Given this list of marker genes Il23r, Erap1, Spred1, Adam8, Smad3, Il3, Snx25, Nsmaf (NCBI Gene Id 93775), Ntf5, Ifna4, Trim37, Ccl22, Cxcl11, Ltb, Tslp, Tnfsf14, Bex3, Gm6040, Prl7a2, Defb47, Ccl8 (NCBI Gene Id 80561), Cxcl3, Cnih4, Eng, Smurf2, Il36a, Prl7a1, Ripk1, Ccl24, Tgfbr3l, Ccl2, Ifna9, Syk, Tgfb3, Ifng, Eda, Defb15, Ccrl2, Crlf1 (cytokine receptor-like factor 1), Ifna12, Stap1, Dnaja3, Gm13272, Gm13283, Pgf, Cd2ap, Pycard, Fadd, Prl3d2, Ccl3, Il10, Tgfbrap1, Ctf2, Ifnl3, Defb48, Msmp, Ifnz, Tgfb2, Pf4, Cd300lf, Ccl17, Cxcl17, Il27, Jak2, Ccl20, Tnfsf12, Cxcl15, Snx6, Prl6a1, Cd40lg, Tgfbr1, Ccl5, Prl5a1, Defb8, Traf2, Traf4, Xcl1, Smad6, Ccl19, Ccl27a, Tlr5 (NCBI Gene Id 53791), Spred3, Ifna13, Zfp110, Tollip, Sh2b3, Il6ra, Ccdc88a, Vegfc, Bdnf, Casp3, Ntrk1, Plcg1, Prl2c2, Ccl1, Ccl19-ps1, Nradd, Ccl4, Csf1, Ddt, Tnfsf4 (NCBI Gene Id 226545), Ccl27b, Il2, Il20, Il17f, Vegfa, Usp15, Casp8, Traf6, Edaradd, Socs1, Lrg1, Il12a, Gdnf (glial cell line derived neurotrophic factor), Ccl11, Il1f10, Lefty1, Vegfd, Ifna15 (NCBI Gene Id 242517), Defb40, Smad2, Cflar, Cdh5, Il1a, Tgfbr2, Jak1, Defb46, Cx3cl1, Tnfsf11, Prl3d1, Irak4, Prl8a2, Prl7d1, Prl7b1, Cxcl13, Ccl26, Ccl6, Angpt2, Prl4a1, Tmbim1, Il23a, Cxcl14, Il9, Prl8a8, Cntf, Efna5, Traf5, Trip6, Tgfbr3, Prl3c1, Nup85, Il6st, Rnf41, Irak1, Prl7c1, Nol3, Ifna7, Gata3, Ccr2, Cxcl12, Cxcl16, Epo, Cxcl10, Prl3b1, Defb7, Babam2, Ccl21a, Angpt1, Lta, Socs3 (NCBI Gene Id 12702), Tnfsf13, Fem1b, Prl3d3, Prl, Prl2a1, Il1b, Ccl27al, Nars1 (asparaginyl-tRNA synthetase 1), Sdcbp, Defb3, Ntf3 (neurotrophin 3), Ccl19-ps6, Ccl19-ps5, Defb38, Rasl11b, Shc1, Zfp369, Ptpn6, Il12b, Tnfsf10, Defb39, Ngf (NCBI Gene Id 18049), Cxcl2, Tnfsf18, Timm50, Il11, Ifna11, Defb10, Tnfsf15, Grin2b, Siva1, Ecm1, Defb34, Ctf1, Cxcl1, Il5, Ccl25, Prdm4, Ifnl2, Il25, Ccl19-ps3, Ifnk, Nucb2, Cxcl5, Prl8a6, Cd44, Ifna16, Defb37, Lif, Tnfsf13b, Ifna5, Il34, Ifna2, Tgfb1, Traf1, Prl2c1, Ifna14, Grb2, Csf2, Cx3cr1, Ccl21f, Myd88, Il1rap, Il15, Prl3a1, Ifne, Smad7, Ifna6, Itch, Tlr9, Il4, Nes, Il1rn, Ppbp, Pdcl3, Gm13275, Itgb3, Prl2b1, Ccl12, Cadm4, Tradd, Gm13276, Adam17, Traf3, Map3k7, Defb9, Ebi3, S100a14, Defb2, Tyk2, Lefty2, Spred2, Defb11, Il7 (interleukin 7), Ngfr, Dab2ip, Tnf, Il13, Gh, Gm13271, Il12rb1, Pik3r1, Csf3, Cklf, Tnfsf8, Angpt4, Defb5, Il21, Cish, Prl2c3 (NCBI Gene Id 26421), Lyn, Tnfsf9 (tumor necrosis factor (ligand) superfamily, member 9), Ifnab, Defb14, Gpr15lg, Il36rn, Fermt2, Prl8a1, Defb1, Il33, Grem1, Ticam2, Mif, Socs2, Ccl9, Defb6, Osmr, Lifr, Il31 (NCBI Gene Id 76399), Ifnb1, Defb33, Cd70, Clcf1, Defb4, Stat1, Pibf1, Fkbp1a (FK506 binding protein 1a), Osm, Cxcl9, Creb3, Ccl28, Tff2, Prl8a9, Ccl21e, Frs2, Prl2c5, Ceacam1, Ccl21d, Il18, Smurf1, Jak3, Hsd17b7, Ccl19-ps4, Ccl7, Ifna1, Ccl21b, Il6, Gm13277 (predicted gene 13277), Fasl, Vegfb, Amh, Stat3 (NCBI Gene Id 68733), Kitl, here is a description of the gene set: studied in species Mus musculus Binding to a cytokine receptor. Mouse Gene Set: GOMF_CYTOKINE_RECEPTOR_BINDING